Given this list of marker genes NARF, UBE2S, RASSF3, TRAPPC6B, PI4KB, RAVER1, TRAT1, ARHGAP5, FMR1, RUNX3, MALL, ALDH4A1, CLCA4, RAB8A, TSPAN13, KCNA3, E2F4, TCF25, ATP1B1, GNB1, RBM17, ICOSLG, SERTAD3 (NCBI Gene Id 29946), TBL1X, AP4E1, ZNF518A, HAUS2, COX8A, VIPR1, IL21R, CCNI, PXYLP1, ILF2, PPIE, GTF2H1, EIF4B, ELOVL7, SCAMP3, ERCC2, BTF3, SPINT2, C1QL1 (NCBI Gene Id 10882), NCSTN, AKTIP, TSNAX, CHMP6, AHCTF1, KLHL21, SEPTIN2 (septin 2), MAZ, CRLF3, VRK2, KATNAL1, MYH9, SCML4, WDR1, ZC3H18, NUB1, KDM3B, RBM25, UBTD1, CDKN2AIP, KCNAB2, NT5C2, MIDEAS, RNF122, GALNT6, HS3ST3B1, UFD1, NSA2, BICRAL, STAMBP, PRPF4 (pre-mRNA splicing tri-snRNP complex factor PRPF4), ENTPD6, PACS2, FTH1, UBE2I, MTERF1, CIRBP, ACAP3, CD7, TP53, RNF220, NSD3, ZNF141, MRPL55, FLI1, ERF (ETS2 repressor factor), LARP1, TSC22D3, CD200R1, ACTR2, HNRNPL, SDHAF4, GPBP1L1, ELF4, TIMM10B, ANXA11, ACOX3, ZNF146, HID1, OS9, PRAF2, NUP54, GRAMD2B, CCDC71, HNRNPA1, SLC16A5, ASB8 (NCBI Gene Id 79076), PATJ, LEF1, ATIC, DVL2, STAU1, HNRNPD, WDR43, PCED1B, POLR3F, USP25, RPF1, ARPC4, MED16, SAFB, PECAM1, TAPBP, REPS2, EPB41, HLA-DRB1, GIGYF1, ORAI2, PNPLA7, DAPL1, ATF4, TNRC6B, SMN1, SPOP, NTRK3, CD200R1L, GALNS, SLC41A3, QRICH1 (glutamine rich 1), TBC1D16, CD3E (NCBI Gene Id 916), RNF125, G3BP1, CAV2, TMC8, LRRC75B, MAGED1, TASOR2, RIGI, ITGAL, NUTF2, USP28, CBX7, ABCA2, QSOX1 (NCBI Gene Id 5768), NSUN4, SEC61G, NTN5, RGS7, ILKAP, CHADL, PAFAH2, SERTAD2, FLJ13224, SSBP4, C8orf82, ATP8B4, LFNG, SETD1B, CRTAM, ENTR1, THRSP, COL27A1, LSM5, IRF4, RTN4IP1, EPN1, SDHC, PSMB2, PIM2, TAF7, ATP6AP1, LNPK, CCAR2, GFM2, ANAPC13, RPA3, SDS, ARHGAP30, PADI6, IFNGR2 (interferon gamma receptor 2), ADRB2, NUDCD2, ARMC7, MKS1, PPP4R3A, STIM1, HNRNPU, here is a description of the gene set: STAT3, an essential transcription factor with pleiotropic functions, plays critical roles in the pathogenesis of autoimmunity. Despite recent data linking STAT3 with inflammatory bowel disease, exactly how it contributes to chronic intestinal inflammation is not known. Using a T cell transfer model of colitis we found that STAT3 expression in T cells was essential for the induction of both colitis and systemic inflammation. STAT3 was critical in modulating the balance of T helper 17 (Th17) and regulatory T (Treg) cells, as well as in promoting CD4+ T cell proliferation. We used chromatin immunoprecipitation and massive parallel sequencing (ChIP-Seq) to define the genome-wide targets of STAT3 in CD4+ T cells. We found that STAT3 bound to multiple genes involved in Th17 cell differentiation, cell activation, proliferation and survival, regulating both expression and epigenetic modifications. Thus, STAT3 orchestrates multiple critical aspects of T cell function in inflammation and homeostasis. Human Gene Set: GSE21670_TGFB_VS_TGFB_AND_IL6_TREATED_CD4_TCELL_DN from publication Durant L, Watford WT, Ramos HL, Laurence A, Vahedi G, Wei L, Takahashi H, Sun HW, Kanno Y, Powrie F, O'Shea JJ (PMID 20493732) studied in species Homo sapiens Genes down-regulated in CD4 T cells: TGF beta versus TGF beta and IL6.